The following is a description of a gene set: Binding to a polysaccharide, a polymer of many (typically more than 10) monosaccharide residues linked glycosidically. Mouse Gene Set: GOMF_POLYSACCHARIDE_BINDING species: Mus musculus, and this is the list of marker genes: Ppp1r3b, Agl, Clec7a, Stbd1, Endou, Ppp1r3f, Reg4, Epm2a, Ppp1r3a, H2-Ea, Clec4g, Fcnb, Gpcpd1, Clec18a, Ppp1r3d, Ppp1r3e, Enpp1, Klrh1, H2-Eb2 (NCBI Gene Id 631971), Ppp1r3c, Cd209b, H2-Eb1, Vtn, Ptx3 (NCBI Gene Id 99687), Ppp1r3g, Enpp2, Prg4, Mbl1